The following is a description of a gene set: species: Mus musculus ErbB signaling pathway Mouse Gene Set: WP_ERBB_SIGNALING_PATHWAY, and this is the list of marker genes: Shc2, Crk, Egfr, Mtor, Gsk3b, Ptk2, Mapk1, Cdkn1a, Cdkn1b, Nrg2, Grb2, Egf, Erbb4, Areg, Btc, Erbb2, Hras, Myc, Mapk8, Nrg3, Jun, Camk2a, Gab1, Bad, Prkca, Abl1, Nrg1, Stat5a, Tgfa, Ereg, Eif4ebp1, Akt3, Pik3r5, Erbb3, Nck1, Pak4, Elk1, Araf, Map2k1, Nrg4, Hbegf, Plcg1, Cblc, Sos1, Src, Map2k7